The following is a description of a gene set: This event has been computationally inferred from an event that has been demonstrated in another species.<p>The inference is based on the homology mapping from PANTHER. Briefly, reactions for which all involved PhysicalEntities (in input, output and catalyst) have a mapped orthologue/paralogue (for complexes at least 75% of components must have a mapping) are inferred to the other species. part of: Cell-Cell communication studied in species Mus musculus Reactome Pathway: Nephrin family interactions electronically inferred by orthology from the curated human pathway, and this is the list of marker genes: Kirrel2, Nphs1, Fyn